Given this list of marker genes PGK1, SLC25A32, GAPDH, UTP11, LRRC42, SEC61G, HILPDA, KIF20A, CDKN3, SLC2A1, NDRG1, ESRP1, TPI1, ANKRD37, CORO1C, VEGFA, ENO1, MIF, PFKP, BNIP3, MRPS17, P4HA1, MAP7D1, TUBA1A, AK4, CTSV, ADM, PSRC1, TUBA1C, MRPL15, PNP, MRGBP, ANLN, SHCBP1, ACOT7, MCTS1, LDHA, PSMA7, MAD2L2, MRPL13, PGAM1, CA9, YKT6, CHCHD2, KIF4A, HK2, GPI, DDIT4, SLC16A1, TUBB6, here is a description of the gene set: Hypoxia is a key factor promoting solid tumour progression and resistance to therapy. Hypoxia biomarkers have the potential to predict prognosis and/or benefit from particular interventions. An approach combining knowledge of gene function and analysis of in vivo co-expression patterns was used to derive a gene expression signature of hypoxia. Specifically, previously validated hypoxia-regulated genes (seeds) were used to generate a co-expression network. To guarantee generality and robustness of this network, bootstrap was used to select genes that were consistently co-expressed with the hypoxia seeds in multiple cancers cohorts and across cancer types (three head and neck and five breast cancer clinical cohorts were used in this phase). Genes with the highest connectivity in the resulting co-expression gene network were extracted to form a hypoxia gene signature. This signature was highly enriched for hypoxia-regulated pathways, enriched for targets of the Hypoxia-Inducible Factor (HIF)-1 as determined in ChipSeq and HIF know-down experiments, and prognostic. Validation in independent data sets of head and neck, breast and lung cancer showed that this signature outperformed previously reported hypoxia gene signatures. Common genes regulated by hypoxia across multiple head and neck and breast cancer clinical cohorts, and prognostic in multiple cancer types from publication Buffa FM, Harris AL, West CM, Miller CJ (PMID 20087356) species: Homo sapiens Human Gene Set: BUFFA_HYPOXIA_METAGENE